The following is a description of a gene set: Any process that stops, prevents, or reduces the frequency, rate or extent of striated muscle cell differentiation. species: Mus musculus Mouse Gene Set: GOBP_NEGATIVE_REGULATION_OF_STRIATED_MUSCLE_CELL_DIFFERENTIATION, and this is the list of marker genes: Ccn3, Msx1, Nkx2-5, Plpp7, Trim72, Ccnd2, Ankrd2, Hdac4, Tomm70a, Ybx1, Bmp2, Rpl3l, Bdnf, Yy1, Ctdp1, Hdac3, Pak1, Gsk3a, Xbp1, Ppara, Hdac5, G6pd2 (NCBI Gene Id 14382), Bhlha15, Zfp418, Notch1, Fzd7, G6pdx, Daxx, Dkk1, Cav3 (NCBI Gene Id 12391), Pi16, Bhlhe41, Csf1r, Frs2 (fibroblast growth factor receptor substrate 2), Rgs2, Smad4, Ezh2, Tmem119, Myocd (myocardin), Rbm10, Sox6, Rgs4, Foxp1, Dll1